Given this list of marker genes Gtf2f2 (NCBI Gene Id 68705), Fgf23, Fgf15, Fgfrl1, Gab1, Polr2c, Fgf2, Grb2, Mapk3, Flrt1, Ptbp1, Shc1, Fgfbp1, Gipc1, Fgf22, Fgf8, Fgf16, Fgf5, Spry2, Cbl, Kl, Frs2, Fgfbp3, Flrt2, Polr2i, Fgf17, Fgf1, Klb, Polr2k, Hras, Fgf4, Ubb, Polr2e, Gtf2f1, Fgf20, Fgf7, Polr2b, Polr2f, Polr2a, Polr2l, Rps27a, Fgf6, Fgf10, Fgfr1, here is a description of the gene set: part of: Signaling by Receptor Tyrosine Kinases studied in species Mus musculus This event has been computationally inferred from an event that has been demonstrated in another species.<p>The inference is based on the homology mapping from PANTHER. Briefly, reactions for which all involved PhysicalEntities (in input, output and catalyst) have a mapped orthologue/paralogue (for complexes at least 75% of components must have a mapping) are inferred to the other species. electronically inferred by orthology from the curated human pathway Reactome Pathway: Signaling by FGFR